The following is a description of a gene set: studied in species Homo sapiens Human Gene Set: REACTOME_REGULATION_OF_MITF_M_DEPENDENT_GENES_INVOLVED_IN_DNA_REPLICATION_DAMAGE_REPAIR_AND_SENESCENCE Regulation of MITF-M-dependent genes involved in DNA replication, damage repair and senescence, and this is the list of marker genes: BRCA1, TERT, MCM5, LIG1, MITF, MCM2